The following is a description of a gene set: Self-injurious behavior species: Homo sapiens Self-aggression. Human Gene Set: HP_SELF_INJURIOUS_BEHAVIOR, and this is the list of marker genes: CRX, TUBB4B, GRIA3, IFNG, ABCA12, GLS, CRBN, ASPM, NAT8L, SMARCC2 (SWI/SNF related, matrix associated, actin dependent regulator of chromatin subfamily c member 2), FBXW11, SLC32A1, NDE1, BRD4, IMPDH1, KCNA1, SNORD115-1, UBE2A, RFX7, FOXP1, NMNAT1, RNU4-2, WAC, ODC1, CASZ1, EP300, TMEM147, ADA2, GDF6, AUH (NCBI Gene Id 549), RNU7-1, CRB1, SATB2, SIM1, SLC6A17 (solute carrier family 6 member 17), NEUROD2, ACBD6 (acyl-CoA binding domain containing 6), SPEN (spen family transcriptional repressor), KCNJ13, GABBR2, RPS6KA3, TBC1D23, HDC, INPP5E, ELP2, PNKP, TSC2, SLC6A4 (NCBI Gene Id 6532), CDC42BPB, PDPN, NPAP1, SKI, DPYD, PIGP, GRIN1, GJA5, NRCAM, UBE4B, THOC2, HNRNPH2, AP1G1, RPE65, NDN, RLIM, SOX5, PRDM16, HTR2A, EIF4A2, GUCY2D, HSPG2, CTNNB1, SLITRK1, IQSEC2, NIPA1, GABRD, EEF1A2, MYT1L, CASK, GRIA2, NIPA2, WDR62, AHDC1, RHOBTB2, HERC2, SNORD116-1, GRIA1, LCA5, MADD, PWAR1, PRKCZ (NCBI Gene Id 5590), KCNAB2, C12orf57, AIPL1, CHD7, ATG7, CDH2, NDST1, SMG8, TKT, ARX, OPHN1, PIDD1, BCOR, TAOK1, HPRT1, TRIM8, NAA80, MAGEL2, ATP1A1 (ATPase Na+/K+ transporting subunit alpha 1), TAF4, MKRN3, TSC1, MGAT2, KIF15, TMEM231, PCYT1A, OCA2, SNRPN, FLII, TUBG1, UNC80, VPS13A, GNAO1, SHQ1, NEUROG1, GRM7, PPP2CA, AFG2A, AP1S2, CLCN4, EHMT1, ALDH5A1 (aldehyde dehydrogenase 5 family member A1), RD3, HECW2, UBAP2L, SETBP1, GATAD2B, NAA10, GJA8, CLCN3, CREBBP, CHD5, ALG14, RDH12, CEP104, SLC1A4, MAPK1, RBL2, RPL10, NFIX, BCL11A, SCAF4, CEP152, RAI1, ASL, RPGRIP1, PAH, NIPBL, SVBP, SYT1, TULP1, IQCB1, CEP290, FAT4 (NCBI Gene Id 79633), CLTCL1 (clathrin heavy chain like 1), DEAF1, KMT2E, SCN2A, CNTNAP2, CAMK2G, PIGQ, PIGF, NTNG2, KMT2C, KAT5, H4C5, KARS1, ATP6V0A1, VAMP2, TRIO, TMCO1, FMR1, MBD5, DNM1, KPTN, DPAGT1, DNM1L (NCBI Gene Id 692222), NEXMIF, SIK1, IFT140 (NCBI Gene Id 9742), CHKA, ATRX, GJB2, ADSL, ASXL3, KIF5C, NTRK1, TCF4, CDKL5, ALG13, LRAT, CHD8, GAMT, OCRL, HDAC4, SLC6A8, NALCN, USP45, SPATA7, SPOP, RERE, WASF1, TREX1, DMXL2, TTI1, POGZ, DCHS1, SLC25A22, MAOA, LUZP1, PWRN1, NDP, RTTN, DHCR7, LARP7, WASHC4, ZBTB20, USP7, MMP23B, SCN1B